Given this list of marker genes SPX, WNK1, RARRES2, ENG, PTPN1, AVP, AVPR2, HSD11B2, AVPR1A, ACE, MANF, CYBA, NMU, ADORA1, NR2F2, RHOA, CYP11B2, here is a description of the gene set: Human Gene Set: GOBP_POSITIVE_REGULATION_OF_SYSTEMIC_ARTERIAL_BLOOD_PRESSURE The process that increases the force with which blood travels through the systemic arterial circulatory system. species: Homo sapiens